The following is a description of a gene set: species: Mus musculus Mouse Gene Set: GOBP_REGULATION_OF_DENSE_CORE_GRANULE_TRANSPORT Any process that modulates the frequency, rate or extent of dense core granule transport., and this is the list of marker genes: Map2 (NCBI Gene Id 17756), Mapk8, Mecp2, Trim46, Eipr1